The following is a description of a gene set: Human Gene Set: REACTOME_ACTIVATION_OF_PUMA_AND_TRANSLOCATION_TO_MITOCHONDRIA studied in species Homo sapiens Activation of PUMA and translocation to mitochondria, and this is the list of marker genes: TP53BP2, BBC3, TP63, TFDP1, TFDP2, PPP1R13B, E2F1, TP73, TP53